Given this list of marker genes Gria3, Grip1, Tspan7, Ap2a2, Gria2, Ap2s1, Gria4, Prkcg, Ap2m1, Grip2, Gria1, Ap2a1, Pick1, Prkcb, Nsf, Ap2b1, here is a description of the gene set: Trafficking of GluR2-containing AMPA receptors species: Mus musculus Mouse Gene Set: REACTOME_TRAFFICKING_OF_GLUR2_CONTAINING_AMPA_RECEPTORS